Given this list of marker genes Nkx2-2, Arx, Pou3f4 (POU domain, class 3, transcription factor 4), Isl1, Pax6, Mafa, Mafb, Neurod1, Mlxipl, Pax4 (paired box 4), Neurog3, Nkx6-1, Myt1, Vdr, here is a description of the gene set: from publication Zhou Q, Brown J, Kanarek A, Rajagopal J, Melton DA (PMID 18754011) Transcription factors expressed in progenitors of endocrine pancreatic cells. studied in species Mus musculus One goal of regenerative medicine is to instructively convert adult cells into other cell types for tissue repair and regeneration. Although isolated examples of adult cell reprogramming are known, there is no general understanding of how to turn one cell type into another in a controlled manner. Here, using a strategy of re-expressing key developmental regulators in vivo, we identify a specific combination of three transcription factors (Ngn3 (also known as Neurog3) Pdx1 and Mafa) that reprograms differentiated pancreatic exocrine cells in adult mice into cells that closely resemble beta-cells. The induced beta-cells are indistinguishable from endogenous islet beta-cells in size, shape and ultrastructure. They express genes essential for beta-cell function and can ameliorate hyperglycaemia by remodelling local vasculature and secreting insulin. This study provides an example of cellular reprogramming using defined factors in an adult organ and suggests a general paradigm for directing cell reprogramming without reversion to a pluripotent stem cell state. Mouse Gene Set: ZHOU_PANCREATIC_ENDOCRINE_PROGENITOR